The following is a description of a gene set: The process whose specific outcome is the progression of the renal vesicle over time, from its formation to the mature structure. An epithelium is a tissue that covers the internal or external surfaces of an anatomical structure. The renal vesicle is the primordial structure of the nephron epithelium, and is formed by the condensation of mesenchymal cells. Mouse Gene Set: GOBP_RENAL_VESICLE_DEVELOPMENT studied in species Mus musculus, and this is the list of marker genes: Stat1, Ctnnb1, Grem1, Osr1, Pax2, Sox8, Sall1, Fmn1, Pax8, Lhx1, Sox9 (NCBI Gene Id 70015), Cited1, Lif (leukemia inhibitory factor), Wnt9b, Six2, Smo, Hey1, Kif26b, Wnt4 (NCBI Gene Id 22417), Gdnf